The following is a description of a gene set: species: Homo sapiens Human Gene Set: MIR6738_3P Genes predicted to be targets of miRBase v22 microRNA hsa-miR-6738-3p in miRDB v6.0 with MirTarget v4 prediction scores > 80 (high confidence targets). from publication Chen Y, Wang X (PMID 31504780), and this is the list of marker genes: PRMT2, MAGEA5P, FMN1 (formin 1), GATA3, PROM2, CBFB, PPM1K, CA12, OXNAD1, PRDM2, HELZ, GNAS, FRMD7, RAB37, BRD8, TM9SF2, ZFP91, GRID2, CRHBP, ADAMTS5, PIBF1, POLH, SLC5A3, TMEM232, CDY1, IGF2BP1, YAP1, NUFIP2, DPPA4, PYGO2, PGD, THSD7B, ZCCHC2, TRPV3, EML4, LRRC2, YTHDF1, PLB1, OSBPL2, COL14A1, AMER2, ARL13A, SRPRB, DIXDC1, CCNG2, USP9X, DNAJC1, CHGB (chromogranin B), RAPH1, NIPBL, PSMC2, RNF212B, GNAL, TXLNB, ZBTB34, APPBP2, RPRD1B, DSC3, PAK5, C1orf56, CDY1B, PPARA, CFLAR, TENM1, HMG20A, TRAM2, GARIN2, NFIB, ATP2A2, ANKRD42, EXOSC3, TCAF2, TEAD1, SYNPO2, ATP11A, PHIP, ENSG00000266560 (novel transcript), HYCC2, YME1L1, SIRT5, USP48, WDR48, AR, TNFAIP8L3, GSPT1, TGFBR1, NIPA2, KIAA0513, MOCS2, PALLD, GXYLT1, SHLD1, SCAI, CSTF3, NR4A3, VPS35L, LRRC28, STRAP, DENND1B (NCBI Gene Id 54530), CCDC126, ANO8, ESR2, KIAA1549L, FLRT1, MYH14, DENND11 (DENN domain containing 11), YWHAZ, UBE2L3, ATP23, FAM78A, ZNF215, TMEM158, NRG4, TUT4, NAA15, HTR1A, PRR4, FUT4, MAPK8, LMBR1, NOTCH1, BPTF, GPR107, CHSY1, ADGRL3, VSTM4, UFL1, WDFY3, CTDP1, ZNF439, RYK, AAK1, ODC1, CIPC, SLC6A4, SYCE2, KDM3A, TMEM167A, FLNB (filamin B), SPTY2D1, ATRX, TMEM178B, ASB5, SCN8A, CAPS2, FUT9, BOD1L1, RAB23 (RAB23, member RAS oncogene family), ZFHX3, NCOR2, NAPB, SLC30A7, YY1, PSAP, KBTBD4, DUSP2